The following is a description of a gene set: UDP-N-acetylglucosamine--dolichyl-phosphate N-acetylglucosaminephosphotransferase (DPAGT1) catalyses the initial committed step in the biosynthesis of dolichyl pyrophosphate-oligosaccharides. Defects in DPAGT1 cause congenital disorder of glycosylation 1j (DPAGT1-CDG, previously known as CDG-1j; MIM:608093), a multisystem disorder characterised by under-glycosylated serum glycoproteins. Congenital disorders of glycosylation result in a wide variety of clinical features, such as defects in the nervous system development, psychomotor retardation, dysmorphic features, hypotonia, coagulation disorders, and immunodeficiency. Defects in DPAGT1 can also cause myasthenic syndrome, congenital, with tubular aggregates, 2 (CMSTA2; MIM:614750), characterised by muscle weakness of mainly the proximal limb muscles, with tubular aggregates present on muscle biopsy. Sufferers find walking difficult and fall frequently. Younger sufferers show hypotonia and poor head control. A disorder of neuromuscular transmission is detected on electromyography. part of: Diseases associated with N-glycosylation of proteins studied in species Homo sapiens Reactome Pathway: Defective DPAGT1 causes CDG-1j, CMSTA2, and this is the list of marker genes: DPAGT1